Given this list of marker genes MGC16275, CRELD2, ZPBP, CDC42SE1, ECHDC2, here is a description of the gene set: from publication Nick JA, Coldren CD, Geraci MW, Poch KR, Fouty BW, O'Brien J, Gruber M, Zarini S, Murphy RC, Kuhn K, Richter D, Kast KR, Abraham E (PMID 15339848) Recombinant human activated protein C (rhAPC) is a natural anticoagulant with potentially important anti-inflammatory properties. In humans with severe sepsis, rhAPC treatment reduces mortality, but mechanisms responsible have not been well characterized. Accumulation of activated neutrophils in the lungs and other organs during severe infection contributes to sepsis-induced organ dysfunction, including acute inflammatory lung injury. Because neutrophils express an APC receptor, we hypothesized that immunomodulatory effects of rhAPC occur, in part, via modulation of neutrophil responses. To examine this issue, we performed a double-blinded, placebo-controlled study of rhAPC in a human model of endotoxin-induced pulmonary inflammation. Administration of rhAPC significantly reduced leukocyte accumulation to the airspaces, independent of pulmonary cytokine or chemokine release. Neutrophils recovered from bronchoalveolar lavage fluid of volunteers receiving rhAPC demonstrated decreased chemotaxis ex vivo. Decreased neutrophil chemotaxis following exposure to rhAPC was confirmed in vitro. No differences were detected in gene expression, kinase activation, cytokine release, cell survival, or apoptosis of neutrophils recovered in the presence or absence of rhAPC. These studies demonstrate that rhAPC reduces both endotoxin-induced accumulation of leukocytes in the airspaces and neutrophil chemotaxis. These rhAPC-induced effects on neutrophil function may represent a mechanism by which rhAPC improves survival in patients with sepsis. Genes up-regulated in neutrophils upon treatment with activated protein C (PROC) of pulmonary inflammation induced by bacterial lipopolysaccharide (LPS). Human Gene Set: NICK_RESPONSE_TO_PROC_TREATMENT_UP studied in species Homo sapiens